Given this list of marker genes CD24, VTCN1, BCAS1, ANXA3, CORO2A, EFEMP1, RAP1GAP, ZNF704 (NCBI Gene Id 84737), RAB26, H2BC4, ABCG1, SOX9, TP53INP2, NANOS1, TSC22D3, CLEC3A, ARL15, TMEM45B, TMTC2 (NCBI Gene Id 160335), TNS3, SELENBP1, ATP8A1, IQGAP2, ZNF750, KCNJ13, MB, KMO, ERBB2, CYFIP2, NELL2, CYP1A1, CEACAM6, ATP6V0A4 (ATPase H+ transporting V0 subunit a4), MME, BEX4, ATP2C2, NDRG1, NPNT (nephronectin), CDKN2B, SMIM5, NECTIN4, SLC12A2, PRSS8, KRT86, ELF3, here is a description of the gene set: As one of the most successful cancer therapeutic targets, estrogen receptor-alpha (ER/ESR1) has been extensively studied over the past few decades. Sequencing technological advances have enabled genome-wide analysis of ER action. However, comparison of individual studies is limited by different experimental designs, and few meta-analyses are available. Here, by ingesting large amount of E2-related transcriptomic data sets in breast cancer cell lines, we identified gene expression changes across 66 RNA-seq and 80 microarray experiments based upon the E2-induced fold change in gene expression. Among the 146 merged transcriptomic datasets, 27 different time points were annotated spanning from 5 minutes to 600 hours of estrogen stimulation. We separated all the comparisons into three signatures of duration: EstroGene_Early (≤6 hours, n = 58), EstroGene_Mid (6-24 hours, n = 44) and EstroGene_Late (≥ 24 hours, n = 44). Upregulated and downregulated genes present in the top 10th percentile of regulated genes in each individual study, and consistently present across at least 50% of studies at each time period, were extracted from each signature (early, mid, and late) and intersected accordingly. We identified 165, 59 and genes representing early, mid, and late estrogen response signatures, respectively. from publication Li Z, Li T, Yates ME, Wu Y, Ferber A, Chen L, Brown DD, Carroll JS, Sikora MJ, Tseng GC, Oesterreich S, Lee AV (PMID 37272757) studied in species Homo sapiens Human Gene Set: LI_ESTROGENE_MID_E2_RESPONSE_DN High confident estrogen down-regulated genes in middle treatment duration (6-24 hours) in breast cancer cells merged from 44 NGS datasets-based comparisons (10% topmost down-regulated genes and consistent in at least 40% comparisons).